The following is a description of a gene set: studied in species Mus musculus from publication Chen Y, Wang X (PMID 31504780) Mouse Gene Set: MIR_582_5P Genes predicted to be targets of miRBase v22 microRNA mmu_miR_582_5p in miRDB v6.0 with MirTarget v4 prediction scores > 80 (high confidence targets)., and this is the list of marker genes: Ubr5, Kpna3, Akap13, Lonrf2, Cav3, Ube2d3, Cnpy3, Ppfia1 (NCBI Gene Id 97413), Zfp800, Epm2aip1, Nrp1, Gspt1, Fam168a, Azin1, Rbm15b, Adam22, Phf6, Cartpt, Ube2h, Pde7a (NCBI Gene Id 99869), Cdyl, Radx, Map4k5, Scn8a, Camsap2, Etfdh, Robo2 (NCBI Gene Id 72126), Rai1, Ppip5k2, Zbtb18, Mrps23, Map7d2, Hapln1, Ypel2, Elovl5, Naa15, Gpr85, Cxxc4, Zfp148, Tex12, Atp10b, Nrep, Npat, Cpne8, Eif4g2 (NCBI Gene Id 77989), Shq1, Mesp2, B3galnt2, Pptc7, Slc8a1, Zmynd8, Zfhx4, Terb2, Metap1, Nfasc, Or6d12, Pln (NCBI Gene Id 18821), Srp19, Stab2, Zmym2, Grip1 (glutamate receptor interacting protein 1), Fermt2, Abtb2, Mindy2, Slc38a2, Smchd1, Abhd17b, Zfp747, Prdm12, B3gat1 (NCBI Gene Id 76898), Wdsub1, Yod1, Ankrd16 (NCBI Gene Id 99042), Fmr1, Slc39a9 (solute carrier family 39 (zinc transporter), member 9), Cd24a, Ppm1e, Mbnl3, Dennd1b, Gpcpd1, Bzw1, Adamts6, Ythdf3, Aptx, Kpna6, Gm4791, Fgf6, Gja1, Rab39b, Ppp4r3b, Zfhx3, Tgoln1, Eif2d, Ercc6l2, Paxbp1, Zfp729b, Shprh, Egfr, Faim, Arg2, Thsd7a, Hif1a, Smc3, Klhl13, Tshz3, Zbtb34, Rock2, Stxbp3, Trappc8, Bcar3, Adamtsl1, Cd81, Frrs1, Taf4, Usf3, Plekhm3, Ino80d, Itprid2, Sox13, Vsx2, Rasl11b, Nhlrc2, Ptpn9, Satb1, Tet3, Ptprz1, Greb1 (NCBI Gene Id 50495), Pex5, Pdcd1lg2, Lsm14a (NCBI Gene Id 67070), Ggct, Colgalt2, Neurl3, Zfp944, Fgf9, Defb1, Enoph1, Cpn2, Lats1, Rnf103, Zfp367, Ccdc71l, Brpf1, Map7d1, Rictor, Jam3, Znrf3, Ccpg1, Srpk2, Cdk17, Flg2, Serpinb2, Kcnab1, Ephb2, Cnst, Epc2, Ipo8, Mro, Zfp322a, Zfp764, Akap11, Cemip2 (cell migration inducing hyaluronidase 2), Etv1, Crebzf, Rev3l, Oga, Gnb4, Snn, Inpp5b, Xkrx, Sfpq (NCBI Gene Id 78315), Adam9 (NCBI Gene Id 11502), Ehmt1, Robo4, Irx2, F8a, Atp2b1, Atp1b1, St6galnac3, Tet2, P2ry1, Rbms3, Lmbrd2, Lrrtm1, Lgr5, Nlk (nemo like kinase), Clec9a, Nacc2, Bclaf1, Ankrd44, Adam12, Dlx5, Fam168b, Sh2d3c, Bcl11b, Mdm2, Shoc2, Arl6ip6, Krtap6-1, Ttll7, Hmgb2, Tbl1xr1, Ints6, Fam91a1, Spag9, Galnt18, Taok1, Yae1d1, Ankrd12, Steap2, Gclc, Nek7, Fbxo33, Elk3, Tnfrsf9, Fryl (NCBI Gene Id 75575), Chd9, Zfp81, Or14j9, Tada2a, Slc4a4, Setbp1, Axin2, Cplx4, Wdr72, Zfp804a, Gnao1, Pitpnc1, Elovl7, Fndc3b, Fbn1, Carf, Ptpn20, Hnf4g, Mapk8, Zfp983